The following is a description of a gene set: The chemical reactions and pathways involving any disaccharide, sugars composed of two monosaccharide units. Mouse Gene Set: GOBP_DISACCHARIDE_METABOLIC_PROCESS studied in species Mus musculus, and this is the list of marker genes: B4galt1, Lalba, Mgam, Lct (lactase), Sis, Treh